The following is a description of a gene set: from publication Weng Y, DiRusso CC, Reilly AA, Black PN, Ding X (PMID 16006652) NADPH-cytochrome P450 reductase (CPR) is an essential component for the function of many enzymes, including microsomal cytochrome P450 (P450) monooxygenases and heme oxygenases. In liver-Cpr-null (with liver-specific Cpr deletion) and Cpr-low (with reduced CPR expression in all organs examined) mouse models, a reduced serum cholesterol level and an induction of hepatic P450s were observed, whereas hepatomegaly and fatty liver were only observed in the liver-Cpr-null model. Our goal was to identify hepatic gene expression changes related to these phenotypes. Cpr-lox mice (with a floxed Cpr gene and normal CPR expression) were used as the control. Through microarray analysis, we identified many genes that were differentially expressed among the three groups of mice. We also recognized the 12 gene ontology terms that contained the most significantly changed gene expression in at least one of the two mouse models. We further uncovered potential mechanisms, such as an increased activation of constitutive androstane receptor and a decreased activation of peroxisomal proliferator-activated receptor-alpha by precursors of cholesterol biosynthesis, that underlie common changes (e.g. induction of multiple P450s and suppression of genes for fatty acid metabolism) in response to CPR loss in the two mouse models. Additionally, we observed model-specific gene expression changes, such as the induction of a fatty-acid translocase (Cd36 antigen) and the suppression of carnitine O-palmitoyltransferase 1 (Cpt1a) and acyl-CoA synthetase long chain family member 1 (Acsl1), that are potentially responsible for the severe hepatic lipidosis and an altered fatty acid profile observed in liver-Cpr-null mice. Genes down-regulated in liver from transgenic mice with reduced expression of POR in all tissues. Human Gene Set: WENG_POR_TARGETS_GLOBAL_DN species: Mus musculus, and this is the list of marker genes: CYP7B1, HSPH1, MGLL, VNN1 (vanin 1), APOA4, HSDL2, CYP4A11, RETSAT, RAD51B (NCBI Gene Id 5890), EGR1, RAB30, SLC22A5, FABP2, GRN, FGL1, HSD17B11, EHHADH, NAA80, ACOT1, HSD17B10, MTAP, ACOT2, ELOVL5, ATF5, CYP2C19